Given this list of marker genes CATSPER4, CCDC65, NEURL1, TSSK4, DPCD, CFAP91, TNP1, SPAG16, DNAI4, SPMIP10, CLXN, CFAP58, CIMIP2C, IRGC, DNAH9, CFAP68, NME5, OFD1, KATNIP, MAFIP, IQUB, TMF1, CFAP221, INTS13, ZMYND12, TPPP2, SPAG6, RIBC2 (NCBI Gene Id 26150), TCTE1, TAC4, BBS2, DDX4, CATSPERZ, CATSPER3, UBE2B, GAS8, CFAP47, CCDC146, SLC22A16, KLC3, DNAAF1, CCDC38, DZIP1 (DAZ interacting zinc finger protein 1), ADAM7, MNS1, CFAP100, LZTFL1, ROPN1, DYNC2H1, RSPH9, EFCAB9, BBS4, TEKTIP1, SPA17 (sperm autoantigenic protein 17), TTLL1, JHY, CFAP95, SEMG2, DEFB1, LDHC, TMEM232, TEKT2, TEX101, TACR3, CABYR, EFHB, SAXO4, POC1B, DNAH5, PLA2G3, VDAC3, CEP78, CFAP276, DUSP21, IFT81, DNAAF5, DNAAF4 (dynein axonemal assembly factor 4), CFAP44, DNAAF11, ATP2B4, GARIN2, CFAP46, VANGL1, GAPDHS, SPMIP8, IQCG, TSSK6, CCDC40, ING2, PRSS55, AKAP4, TTLL6, PRDM14, KIF9, CATSPER1, CCDC103, SPEM1, CFAP43, SORD, CEP128, CIMIP2A, DNAAF3, CCNYL1, CFAP73, CFAP57, PIERCE2, EFCAB6, SPMIP11, ARMC3, GARIN3, SLC9B1, STK36, CFAP210, SPMIP9, INPP5B, HYDIN, DNAH2, NPHP3, BBOF1, NPHP4, TUBB4B, DNAI1, DNAH8, CFAP61, KIF27, TTLL8, MEIG1, ODAD1, NME8, CFAP45, CELF3, CCDC88C, TEKT1, TPGS1, CFAP54, DNAH1, EFHC2, CFAP157, TUBA1A, SPEM3, GAS2L2, SPEF1, GK2, VPS13A, CFAP251, SEPTIN4, CFAP141, C2CD6, DRC1, NHERF1, TTC12, NEK10, TAC1, DAW1, DNAAF6, CFAP53, PGAM4, EFHC1, TTC29, DNAI2, PACRG, CCR6, SLIRP, CFAP206, TTLL3, FSIP2, SMCP, RSPH4A, CFAP298, AQP4, ROPN1L, SLC22A14, CFAP119, TEKTL1, DNAI3, KIAA0319L, ADCY3, CWH43, ARMC2, CFAP144, TEKT5, LRRC46, ARMC12, CCDC39, DNAH6, CFAP77 (cilia and flagella associated protein 77), STARD7, CATSPERD, CFAP52, TAC3, CFAP90, CATSPER2, TACR2, ROPN1B, TTLL9, DNHD1, IQCF1, GMNC, SPAG17, SLC9B2, DNAH3, DNAH10, DNALI1, CFAP70, CFAP65, CFAP126, HOATZ, DNAH7, RSPH6A, ASH1L, DRC7, ZMYND10, RFX3, YIF1B, CCDC63, SPACA9, TEKT4, CELSR2, DNAAF2, CFAP20, DNAH11, RNASE10, APOB, TEKT3, NME7, ODAD3, PGK2, ENKUR, EPPIN, ADCY10, PLTP, SEMG1, CFAP161, DNAH14, PIERCE1, CIMAP1A, PDCL2, TLE6, TBC1D21, ODAD4, RIBC1, DNAH17, ATP1A4, CCDC159, PRM3, AKAP3, CEP131, TTC21A, SPAG8, CFAP107, BBS1, CABS1, ODAD2, CFAP97D1, TACR1, PFN4, SPMIP6, CATSPERE, CAMSAP3, CFAP69, MKKS, TTLL5, CYB5D1, SPEF2, LRRC23, SLC9C1, QRICH2, here is a description of the gene set: Human Gene Set: GOBP_CILIUM_MOVEMENT studied in species Homo sapiens The directed, self-propelled movement of a cilium.